Given this list of marker genes FIS1, BRK1, COMMD7, GPSM2, POLI, ATG3, SERP1, SGPL1, PLEKHF2, NOP56, METTL9 (methyltransferase 9, His-X-His N1(pi)-histidine), CAPZB, MBNL3, RGS10, DRAP1, MYBPC2, PRCP, CAPNS1, NOXRED1, CYP39A1, OTUD5, SELENOW, SSBP3, ANGEL2, TPD52, EPSTI1, TMEM234, LBR, FADS2, BMAL1, NIPSNAP1, POLR1D, CAT, SPTSSA (serine palmitoyltransferase small subunit A), COX7A2L, DCAF5, PNP, ZFAND6, UQCRC1, ENTPD5 (ectonucleoside triphosphate diphosphohydrolase 5 (inactive)), SIGMAR1, CCNI, DHPS, SLC41A2, SMIM14, DTNBP1, TMEM128, RETREG1, BLK, PLPBP, IRAG2, KRCC1, RAB4B, TOMM20, HAAO, CERK, BLVRA (biliverdin reductase A), FAM53A, DNAJC7, ACSS1, ZBTB7A, AKIP1, LGALS1, AICDA (activation induced cytidine deaminase), PDE3B, CLP1, GNAI2, ARHGDIA, GLRX, EIF6, ACOT7, SLC28A2, TUFM, AP2S1, SUSD1, TUBA1A, MAP4K1, CORO1A, GTPBP2, CSK, CD37, XRCC1, SCYL1, EMC4, JPT1, CPM, RDM1, RDH12, PSMB8, RPS23, RGS2, MRPS26, ENOPH1, OMA1, AP1M1, PLEKHO1, SORBS2, ANXA2, TBCA, TCF3, PDE2A, MID1IP1, SKAP2, PELI1, PRKAR2A, LMO2, CENPS, PSMB9, BIN1, ATP2A3, RHOG, CEP15, MLF2, TMEM9B, GNG10, ANTXR2, RNF19B, ILDR1, MYL6, RHOH, GABARAPL2, EIF3H, NEURL3, RPLP2, TIMM17B, ITGB1, UQCRQ, AIP, MICU2, GPS2, UGP2, RAB28, PRPSAP2, MS4A1, UNC93B1, TSPAN13, HIBADH, NUBP2, OGFRL1 (NCBI Gene Id 79627), MICOS10, BEND5, SMAGP, GLUD1, TTC7B, UBE2G1, GNA15, RIPK3, MRPS33, SPATA6, H1-0, PPM1M, BUB3, SLC25A11, UQCC1 (NCBI Gene Id 55245), DOK3, PRKRIP1, NMI, KRT222, FTH1, CSRP2, NECAP2, PARK7, MED16, ITGB7, CDK9, RGS18, RNF115, CCDC134 (NCBI Gene Id 79879), CALM1, LYPLA2, ANAPC2, ADA, TXN, TRAF1, FCRLA, VDAC2, ALDH2, ATF4, TMEM242, ACTR3, HLA-B, HSDL2, IRF3, POLD4 (DNA polymerase delta 4, accessory subunit), TSPO, here is a description of the gene set: from publication Dudziak D, Kamphorst AO, Heidkamp GF, Buchholz VR, Trumpfheller C, Yamazaki S, Cheong C, Liu K, Lee HW, Park CG, Steinman RM, Nussenzweig MC (PMID 17204652) Human Gene Set: GSE6259_DEC205_POS_DC_VS_CD8_TCELL_UP Dendritic cells (DCs) process and present self and foreign antigens to induce tolerance or immunity. In vitro models suggest that induction of immunity is controlled by regulating the presentation of antigen, but little is known about how DCs control antigen presentation in vivo. To examine antigen processing and presentation in vivo we specifically targeted antigens to the two major subsets of DCs using chimeric monoclonal antibodies. Unlike CD8+ DCs that express the cell surface protein CD205, CD8- DCs, which are positive for the 33D1 antigen, are specialized for presentation on MHC class II. This difference in antigen processing is intrinsic to the DC subsets and associated with increased expression of proteins associated with MHC processing. species: Homo sapiens Genes up-regulated in splenic DEC205+ dendritic cells versus CD8 T cells.